Given this list of marker genes Cenph, Cenpw, Cenpc1, Cenps, Cenpm, Cenpt, Cenpp, Cenpn, Cenpu (NCBI Gene Id 71876), Cenpi, Orc2 (NCBI Gene Id 98596), Cenpq, Itgb3bp, H3f3a (NCBI Gene Id 15078), Cenpo, Cenpx, Cenpk, Cenpl, here is a description of the gene set: Mouse Gene Set: GOCC_INNER_KINETOCHORE The region of a kinetochore closest to centromeric DNA which contains many CENP proteins organized in various subcomplexes including CENP-C, CENP-LN, CENP-HIKM, CENP-OPQUR and CENP-TWSX, but excluding the CENP-A containing heterochromatin. studied in species Mus musculus